The following is a description of a gene set: Genes translationally up-regulated by serum in MEF cells (embryonic fibroblast) lacking TSC2. Human Gene Set: BILANGES_SERUM_SENSITIVE_VIA_TSC2 from publication Bilanges B, Argonza-Barrett R, Kolesnichenko M, Skinner C, Nair M, Chen M, Stokoe D (PMID 17562867) studied in species Mus musculus The tuberous sclerosis complex (TSC) proteins TSC1 and TSC2 regulate protein translation by inhibiting the serine/threonine kinase mTORC1 (for mammalian target of rapamycin complex 1). However, how TSC1 and TSC2 control overall protein synthesis and the translation of specific mRNAs in response to different mitogenic and nutritional stimuli is largely unknown. We show here that serum withdrawal inhibits mTORC1 signaling, causes disassembly of translation initiation complexes, and causes mRNA redistribution from polysomes to subpolysomes in wild-type mouse embryo fibroblasts (MEFs). In contrast, these responses are defective in Tsc1(-/-) or Tsc2(-/-) MEFs. Microarray analysis of polysome- and subpolysome-associated mRNAs uncovered specific mRNAs that are translationally regulated by serum, 90% of which are TSC1 and TSC2 dependent. Surprisingly, the mTORC1 inhibitor, rapamycin, abolished mTORC1 activity but only affected approximately 40% of the serum-regulated mRNAs. Serum-dependent signaling through mTORC1 and polysome redistribution of global and individual mRNAs were restored upon re-expression of TSC1 and TSC2. Serum-responsive mRNAs that are sensitive to inhibition by rapamycin are highly enriched for terminal oligopyrimidine and for very short 5' and 3' untranslated regions. These data demonstrate that the TSC1/TSC2 complex regulates protein translation through mainly mTORC1-dependent mechanisms and implicates a discrete profile of deregulated mRNA translation in tuberous sclerosis pathology., and this is the list of marker genes: NPM3, SPAG5, EIF3A, KIF1B, UBA6, THOC2, SMARCA4, COL1A2, H1-4, ATP1A1, COL3A1, TUBB2B, TBC1D16, GBF1, NEDD4, THBS2, EIF3C, FAM98B (family with sequence similarity 98 member B), DICER1, CCN1, CCDC88A, NUMA1, DDX46 (NCBI Gene Id 9879), INTS15, SNRPD3, KIFC1, EIF5B, FAM234B, SMG6 (SMG6 nonsense mediated mRNA decay factor), GLG1, H2AL3, CCN2